The following is a description of a gene set: Mouse Gene Set: GOMF_MUSCLE_ALPHA_ACTININ_BINDING species: Mus musculus Binding to muscle isoforms of actinin. Muscle alpha-actinin isoforms are found in skeletal and cardiac muscle and are localized to the Z-disc., and this is the list of marker genes: Pkd2, Prickle4, Synpo2, Ttn, Mypn, Pdlim4, Pkd2l1, Pdlim5, Pdlim7, Pdlim1, Pdlim2, Pdlim3, Ldb3, Nrap